Given this list of marker genes TUSC2, MIR26A1, MIR136, IL12A, TLR4, TNFSF4, TGFB1, MIR146B, PRNP, FOXP3, NCKAP1L, IL36RN, ARG2 (arginase 2), DDIT3, VSIR, IFNG, MIR20A, MIRLET7F1, MIR181C, IL27RA, MIR135A1, IL12B, MIR383, here is a description of the gene set: Any process that stops, prevents, or reduces the frequency, rate, or extent of production of any member of the interleukin-17 family of cytokines. studied in species Homo sapiens Human Gene Set: GOBP_NEGATIVE_REGULATION_OF_INTERLEUKIN_17_PRODUCTION